Given this list of marker genes SCO2, VPS35L, NHP2, HOXA13, PLAGL1, BUD23, SHOC2, DHX37, HOXC13, TWIST1, NPM1, GDF5, LIG4, SMARCA4, IKBKG, TRIM8, NSUN2, INPPL1, LAMA3, CLIP2, PIGQ, SMARCC2, TERT, SOX9, DLK1, ACTL6B, KRT14, LMNA, TYMS, TOMM7, NOG, SET, APC2, TARS1, MEG3, ERI1, ZNF462, DPYD, EVC, TELO2, NSD1, LIMK1, CTC1, PRKACA, GPC4, SMARCE1, NOTCH1, ATP6V0A2, PARN, SMARCB1, GTF2E2, ADAMTSL2, NCF1, CDKL5, GJB6, TP63, AFF4, LAMB3, TRRAP, PRKACB, DNAJC21 (NCBI Gene Id 134218), CASK, IFT122, CCDC22, PIGF, PEX2, PIGA, EVC2, RSPO4, EOGT, GRIN1, PGAP2, AARS1, PPP2R5D, NEPRO, ZIC3, CENPT, POC1A, SIK1 (NCBI Gene Id 54018), WLS, JUP, RFC2, RBBP8, RTL1, EZH2, POLR1A, GLI1, COL11A1, SLC25A24 (solute carrier family 25 member 24), TCTN3, ZFX, LRP4, GTF2I, DNAJC30, POP1, RPS6KA3, SLC25A22, MCTP2, MMP1, TBX3, GRM7, ZMYM2 (zinc finger MYM-type containing 2), FGFR2, RLIM, APC, BAZ1B, MPLKIP, GTF2H5, RTEL1, TWIST2, TMEM270, SCN1B, FBXO28, PIGN, HMGA2, COL7A1, TSPAN7, NEUROD2, CCDC32, FRAS1, KIF15, MSX1, CPT2, EED, DPYSL5, PIGV, KMT2D, DKC1, IHH, POLR3A, TMEM222, TBL2 (transducin beta like 2), RERE, CDIN1, STX1A, RNF113A, BMPER, CRKL, WASHC5, FLNB, ARHGAP31, SLC32A1, STAMBP, IFT43, KRT5, ALG12, ALOXE3, LAMC2 (NCBI Gene Id 3918), VPS37D, PPP1CB, COL11A2, HUWE1, UBAP2L, PRR12, KCNN3, ATP2A2, ALG3, SUZ12, TERC, GTF2IRD2, LMX1B, WNT10A, WRAP53, SMARCAD1, PIGB, BICRA, VAC14, DMXL2, SOX4, NPR2, FTO, WDR73, RBPJ, CKAP2L, ZBTB20, DPF2, SLC35D1, ITGB4, DOCK6, CDH1, MLXIPL, TBX4, ARID1B, PORCN, DPH1, DYNC2LI1, B3GALT6, RIPK4, SOX11, EIF5A, COL17A1, KDM1A, TFAP2A, ROR2, KCNA1, ATP6V1B2, ALOX12B, DLL4, PTDSS1, PIGW, WNT7A, PIGP, SMARCD1, SMARCA2, BHLHA9, HYMAI (hydatidiform mole associated and imprinted), SPEN, GTF2IRD1, SHANK3, NOP10, METTL27, MBTPS2, ZMPSTE24, PLEC (NCBI Gene Id 5339), KCNH1, ARID2, PIGY, TINF2, NOTCH2, OTUD5, SCN2A, CARS1, HRAS, PGAP3, ACTG2, ERCC2, EBF3, PLAG1 (NCBI Gene Id 7996), PPM1D, ODC1, BCR, FOSL2, USB1, NSDHL, HEPHL1, MAPK1, ERCC3 (ERCC excision repair 3, TFIIH core complex helicase subunit), DPH2, FGFR1, TBC1D24, ELN, FIG4, RSPO1, SIAH1, GRHL2, PIGO, IGF2, GNAO1, NECTIN4, CWC27, ARID1A, EIF4H, DSP, GPC3, PNKP, RAF1, CDKN1C, FKBP6, ARX, SHOX, PIGL, here is a description of the gene set: Human Gene Set: HP_APLASIA_HYPOPLASIA_OF_THE_NAILS Aplasia/Hypoplasia of the nails Aplasia or developmental hypoplasia of the nail. studied in species Homo sapiens